The following is a description of a gene set: CD8+ T cells in chronic viral infections like HIV develop functional defects such as loss of IL-2 secretion and decreased proliferative potential that are collectively termed exhaustion1. Exhausted T cells express increased levels of multiple inhibitory receptors, such as Programmed Death 1 (PD-1). PD-1 inhibition contributes to impaired virus-specific T cell function in chronic infection because antibody-mediated blockade of its ligand, Programmed Death Ligand 1 (PD-L1) is sufficient to improve T cell function and reduce viral replication in animal models. Reversing PD-1 inhibition is therefore an attractive therapeutic target, but the cellular mechanisms by which PD-1 ligation results in T cell inhibition are not fully understood. PD-1 is thought to limit T cell activation by attenuating T cell receptor (TCR) signaling. It is not known whether PD-1 ligation also acts by upregulating genes in exhausted T cells that impair their function. Here, we analyzed gene-expression profiles from HIV-specific CD8+ T cells in patients with HIV and show that PD-1 coordinately upregulates a program of genes in exhausted CD8+ T cells from humans and mice. This program includes upregulation of basic leucine transcription factor, ATF-like (BATF), a transcription factor in the AP-1 family. Enforced expression of BATF was sufficient to impair T cell proliferation and cytokine secretion, while BATF knockdown reduced PD-1 inhibition. Silencing BATF in CD4+ and CD8+ T cells from chronic viremic patients rescued HIV-specific T cell function. Thus inhibitory receptors can cause T cell exhaustion by upregulating genes – such as BATF – that inhibit T cell function. studied in species Homo sapiens Human Gene Set: GSE24026_PD1_LIGATION_VS_CTRL_IN_ACT_TCELL_LINE_UP from publication Quigley M, Pereyra F, Nilsson B, Porichis F, Fonseca C, Eichbaum Q, Julg B, Jesneck JL, Brosnahan K, Imam S, Russell K, Toth I, Piechocka-Trocha A, Dolfi D, Angelosanto J, Crawford A, Shin H, Kwon DS, Zupkosky J, Francisco L, Freeman GJ, Wherry EJ, Kaufmann DE, Walker BD, Ebert B, Haining WN (PMID 20890291) Genes up-regulated in comparison of Jurkat T cells stimulated in the presence of PD-1 versus controls., and this is the list of marker genes: EPAS1, BAMBI, TAP1, RLN1, LCP2, CIC, GPR18, PTPRO, ANXA1, ATP6V0E1, HLA-C, TESPA1, SCN1A, IFIH1, BTN3A2, PPM1F, B2M, CACNA1C, PLAAT4, CD63, RAB27A, KPTN, ZDHHC13, NMI, CD52, IRF1, FASLG, CGA, ANTXR1, ATP6V0E2, ATP5PF (NCBI Gene Id 63498), CCR1, ACOT13, COX6A1, SNRPD2, RER1, TFPT, LRRC23, ISG20, PUS3, ZNF580, GOLT1B, SOD1, JARID2, HLA-A, LGALS1, GSTK1, YPEL1, GTF2H5, NUDT2, GOSR2, UBE2L6, ERAL1, ZNF195, CD28, ANXA2, CAPNS1, CNIH3, PTPRC, CD1C (NCBI Gene Id 911), HOXC8, BCL9, CST7, CSAD, VIM, CLEC2B (C-type lectin domain family 2 member B), BATF3, RPL36, CLIC1, FBXW7, COX6C, TRBC1, CNOT7, HLA-E, SELENOW, NOP10, NDUFA4, UBXN1, CDKL1, EEF1D, SLAMF8, CBR3, MRPS18A, SLC14A1, NOSIP, DYRK4, B3GNT2, MYL11, TARP, DOK2, SHFL, TIMP1, CD58, RRAGA, PSME2, TLX1, PACS1, ABHD11, CES2, PSMB9, FMOD, SLA, AKR1A1, SLC18A2, MYL12B, CCDC28B (coiled-coil domain containing 28B), GRM2, IRF9, BBIP1, COX7B, NMRK1, RPS18, PFDN5, SEC61G, CD3D, SPA17, DYNC2LI1, MUC7, OTOF, PGR, IL10RB (interleukin 10 receptor subunit beta), ABCB9, CES1P1, TMC7, S100A10, FDPS, HMGCS1, MRPS33, LAX1, RPS7, DDAH2, CKS2, C1orf54 (NCBI Gene Id 79630), GBP1, CERS4, GMFG, FAM131B, GSTO1, ENY2, IL7R, BST2, IFI35, MLEC, ASB4, GRB2, SH2D2A, PSME1, MT2A (NCBI Gene Id 4502), STAT1, MXRA7, PRKCE, ALOX5AP, HLA-B, SMAD1 (SMAD family member 1), APOL6, SCCPDH, IFI6, SH3BGRL3, COMMD3, IFIT3, ITM2A, ATP6V1D, COBL, TNFSF10, GSDME, RBM17, ECM1, STAT4, TMEM50B, TRIM21, ENSA, POLD4, LY96 (NCBI Gene Id 23643), CHI3L2, HSD17B7, NT5E, CCRL2, PHLDA1, TRAC, MED6, MT1X, GABARAPL2, PEX2 (NCBI Gene Id 5828), EMP3, GP1BB, MC3R, GZMA (NCBI Gene Id 3001), ZFP30, DCAF16, PSMB10, DEFB1, H3-3B, NDUFA1 (NADH:ubiquinone oxidoreductase subunit A1), RHOH, PSMB8, DNAI4, REX1BD, SLC25A22